The following is a description of a gene set: studied in species Homo sapiens Human Gene Set: GOCC_NLS_DEPENDENT_PROTEIN_NUCLEAR_IMPORT_COMPLEX A dimer consisting of an alpha and a beta-subunit that imports proteins with an NLS into the nucleus through a nuclear pore., and this is the list of marker genes: KPNA2, KPNA7, KPNA3, KPNB1, MYBBP1A, KPNA6, KPNA4, SNUPN (snurportin 1), KPNA1, KPNA5